The following is a description of a gene set: Human Gene Set: HP_ABNORMALITY_OF_THE_MUSCULATURE_OF_THE_LOWER_LIMBS species: Homo sapiens Abnormality of the musculature of the lower limbs, and this is the list of marker genes: ATP13A2, HACE1, SGCG, DYNC1H1, DNM2, GMPPB, SYNE2, FKRP, POMT1, MATR3, KIF1A, VMA21, VPS13A, FRG1, LIMS2, FBN2, FLNC, POPDC3, TCAP, TRIM32, DES, VAMP1, VAPB (NCBI Gene Id 9217), DYSF, ANO10, RASA1, ITPR1, SPAST, MTMR14, DARS2, SRY, CNBP, CAPN3, SYNJ1, TTN, POMT2, LAMA2, CIDEC, SLC25A1, HINT1, WASHC5, CRYAB, PLEC, EMD, LARGE1, ABCD1, PLIN1 (NCBI Gene Id 5346), DHX16, CRPPA, BIN1, PI4KA, ANO5, KIF5A, MICU1, PPARG, ADSS1, VCP, SGCD, NEFL (NCBI Gene Id 4747), MYH7, DAG1, POMK, POMGNT2, AR, MYF6, GNE, PODXL, HMGCR, LMNA, FHL1, SGCA, POMGNT1, DPM3, LDB3, NEB, SGCB, FKTN, DKK1, UNC45B, PMP22 (peripheral myelin protein 22), PNPLA2, LTBP4, CLCN1, SYNE1, REEP1, CAV3, MAP3K20, DNAJC6, HNRNPDL, SMN1, SACS, TRPV4, SPG11, DMD, MT-ATP6, TMEM43, KCNA1 (potassium voltage-gated channel subfamily A member 1), KLHL9, SNUPN, ZFYVE26, BSCL2, SMN2, SPTLC1, LMX1B, RYR1, CHCHD10